The following is a description of a gene set: SP100 was first identified as a nuclear autoimmune antigen and is a constituent of the nuclear body. SP100 interacts with the ETS1 transcription factor, and we have previously shown that SP100 reduces ETS1-DNA binding and inhibits ETS1 transcriptional activity on the MMP1 and uPA promoters. We now demonstrate that SP100 expression is upregulated by interferons, which have been shown to be antiangiogenic, in primary endothelial cells. As ETS1 is functionally important in promoting angiogenesis, we tested the hypothesis that ETS1 activity is negatively modulated by SP100 in endothelial cells. SP100 directly antagonizes ETS1-mediated morphological changes in human umbilical vein endothelial cell (HUVEC) network formation and reduces HUVEC migration and invasion. To further understand the functional relationship between ETS1 and SP100, cDNA microarray analysis was utilized to assess reprogramming of gene expression by ETS1 and SP100. A subset of the differentially regulated genes, including heat-shock proteins (HSPs) H11, HSPA1L, HSPA6, HSPA8, HSPE1 and AXIN1, BRCA1, CD14, CTGF (connective tissue growth factor), GABRE (gamma-aminobutyric acid A receptor epsilon), ICAM1, SNAI1, SRD5A1 (steroid-5-alpha-reductase 1) and THY1, were validated by real-time PCR and a majority showed reciprocal expression in response to ETS1 and SP100. Interestingly, genes that are negatively regulated by ETS1 and upregulated by SP100 have antimigratory or antiangiogenic properties. Collectively, these data indicate that SP100 negatively modulates ETS1-dependent downstream biological processes. from publication Yordy JS, Moussa O, Pei H, Chaussabel D, Li R, Watson DK (PMID 15592518) Human Gene Set: YORDY_RECIPROCAL_REGULATION_BY_ETS1_AND_SP100_DN studied in species Homo sapiens Genes down-regulated in HUVEC cells (endothelium) by ETS1 which were up-regulated by SP100., and this is the list of marker genes: TICAM2, VAV1, CACYBP (calcyclin binding protein), TYW3, CELA3A, BMX (NCBI Gene Id 660), HSPA8, IRF9, PMP22, CFD, DNAJB6, TCL1B, HSPH1, KLF4, TULP4, DNAJB1, CPEB4, PCDH9, CCN3, HSPA1L, SOCS3, TENT5A, MUC4 (NCBI Gene Id 55804), ZNF91, MAGEA9B, CLIC2, IRF4, ZNF532 (NCBI Gene Id 55205), PTGES, PAX2, SSUH2, LRIF1, HADH, LMO7, ZMYND8, MAGEA11, COL4A3, CHL1, ANGPTL4, KLRB1, CNR2, WNT7A, AGO2, SRD5A1, CYB5R2, CHORDC1, SAMD9L, HSPB8 (NCBI Gene Id 8097), AHSA1, PRKCA, PTPRM, TENT5C (terminal nucleotidyltransferase 5C), PHYH, TNC, SPINK1, ZNF578, CELA3B, BRCA1, ALDH1A2, CA2, BTG3, AXIN1, BAG3, RASSF8, TASOR, ERCC6L2 (NCBI Gene Id 56959), FLT3, FKBP4, ESPL1, SNAI1, ZNF106, APOA4